The following is a description of a gene set: The process in which a monocyte acquires the specialized features of a dendritic cell, an immunocompetent cell of the lymphoid and hemopoietic systems and skin. Mouse Gene Set: GOBP_MYELOID_DENDRITIC_CELL_DIFFERENTIATION species: Mus musculus, and this is the list of marker genes: Camk4, Relb, Gimap5, Rbpj, Tnfsf9, Gimap3, Csf2, Batf, Notch2, Ltbr, Dcstamp, Itgb8, Tgfbr2, Psen1, Batf2, Spi1, Tgfb1, Batf3, Il4, Ubd, Irf4, Pirb, Itgb6, Traf6